Given this list of marker genes OXT, FBXL19, TPPP3, FXYD2, CPEB4, PAPOLB, CEMIP2, BRCA2, MEF2C, PGAP6, TRPM2, EXO1 (exonuclease 1), BAZ1A, ITGB2, LSM2, MADCAM1, HJURP, NETO2, GSTM1, API5, SNX10, STRN, LCMT1, KCNC4, RABIF, C9orf78, MAP7D1, SIPA1, NKIRAS2, NDUFAF3, PPP4R1, RDH12, NIBAN1, TRAK2, DOCK7, POC1A, PKN1, RENBP, SNRNP27, BRCA1, NCCRP1, TTLL11, GATAD1, NRIP2, MYADM (myeloid associated differentiation marker), C1QA, RBL1, BMPR1A, TTC32, TM9SF4 (NCBI Gene Id 9777), ACER1, MYL1, SYCP2L (NCBI Gene Id 387105), TXN, ARF1, AXL, BHMT2 (betaine--homocysteine S-methyltransferase 2), CENPM, MYL2, RANBP9, SEPTIN10, HHIP, FOXRED2 (FAD dependent oxidoreductase domain containing 2), SORL1, CCDC146, CMPK1, USP15, CREG1, CDKN1A, MYL4, CXCL3, GRB10, TUBA1B, F3, ACSL6, SREK1IP1, SELENON, ADAMTSL3, HIBCH, TMCO1, CASP3, FGD3, KCNMA1, LRRC8D, ACO2, CEP128, C4orf19, CYB561A3, SLC8B1, YWHAH, PRKCD (protein kinase C delta), HIPK2, TYMS, SASS6, TECR, DUOX1, NFIC, AVPR1A, ADAMTSL2, STK11, YWHAB, SPC24, SLC6A12, COMMD1, GPC1, PWWP2B, MCF2L, ACSBG2, MYO1D, RNF24, MAGI3, GLRX, HSPB2, ARG2, AGTPBP1, NR5A1, TSGA10, LRRC56, MSRB2, SPMIP4, BOC, CCT8L2, CEP76, CEACAM20, ARHGAP23, TMEM179B, PIERCE1, AGFG2, RAD51C, GPI, CARHSP1, IRS2, CDK2, TF, LIMS4, LPGAT1 (lysophosphatidylglycerol acyltransferase 1), SLC22A15 (NCBI Gene Id 55356), MICU1, BORA, SPAG4, TLR4, PTPRK, MAPRE1 (microtubule associated protein RP/EB family member 1), SAP30, SMC1B, KCTD13, NCK1, GPR35, DHRS1, KMT5A, PFN1, SGK3, BMAL2, MSMO1, BLVRB, RASA4, PKM, FBLIM1, CCDC92, LMLN, HMMR, MPP7, PHF10, MFSD6L, WIPI1, RAB20, NHERF2, HOXD9, MPP1, ADA, RALB, SLC25A24, SRSF9, POU1F1, ARHGEF26, HTRA2, PRKAR2A, AGTRAP, TPD52, FBXL13, TEAD3, DKK3, SLC43A3, RPS6KA5, TMEM86A, NEUROG3, BATF2, TSPAN5, VASP, STAG2, MS4A2, AP1S2, CFAP119, CHRM3, OSM, REEP3, TMEM121B, COQ4, LHFPL4, CYP26A1, here is a description of the gene set: Human Gene Set: GSE27786_CD4_TCELL_VS_MONO_MAC_DN from publication Konuma T, Nakamura S, Miyagi S, Negishi M, Chiba T, Oguro H, Yuan J, Mochizuki-Kashio M, Ichikawa H, Miyoshi H, Vidal M, Iwama A (PMID 21540074) species: Homo sapiens Each fraction of mouse hematopoietic cells was purified by cell sorting from bone marrow of 8-week-old C57BL/6 mice, and its gene expression was analyzed. Genes down-regulated in comparison of CD4 T cells versus monocyte macrophages.